Given this list of marker genes Ap2m1, Frs2, Rapgef1, Kras, Cltc, Dusp7, Dnal4, Ralgds, Srf, Pik3ca, Sgk1 (NCBI Gene Id 20393), Mapk1, Ap2b1 (adaptor-related protein complex 2, beta 1 subunit), Mapkapk2, Rps6ka1, Rps6ka5, Ap2a1, Pik3r2, Atf1, Mapkapk3, Rap1a, Mapk7, Egr2, Sos1, Pik3r1, Irs2, Ngf, Mapk14 (mitogen-activated protein kinase 14), Nab2, Rps6ka2 (NCBI Gene Id 436439), Sh3gl2, Dusp3, Hras, Dusp6 (dual specificity phosphatase 6), Ap2a2, Ppp2r5d, Braf, Ppp2cb, Rps6ka3, Clta, Ywhab, Rhoa, Map2k2, Kidins220, Map2k1, Ppp2r1a, Ap2s1, Crk, Dusp4, Pik3cb, Ppp2r1b, Ntrk1 (NCBI Gene Id 97088), Mapk3, Shc3, Creb1, Shc2, Vrk3, Ppp2ca, Grb2 (NCBI Gene Id 14784), Crkl, Chd4, Mapk11, Shc1, here is a description of the gene set: Mouse Gene Set: REACTOME_SIGNALING_BY_NTRK1_TRKA Signaling by NTRK1 (TRKA) species: Mus musculus